The following is a description of a gene set: Human Gene Set: GOCC_CATION_CHANNEL_COMPLEX An ion channel complex through which cations pass. species: Homo sapiens, and this is the list of marker genes: DLG2, KCNMA1, CALM3, ATP5PB, KCNB2, HTR3B, KCNN1, AKAP6, ABCC8 (NCBI Gene Id 6833), CALM1, KCNJ11, ATP5PD, KCNMB1, KCNH1, KCNG2, CATSPER3, TRPV6, GRIK2, PDE4D, KCNN4, SCN11A, KCNJ4, KCNK1, CHRNA6, AMIGO1, SCN9A, KCNA6, KCNK6, CACNA2D1, LRRC55, SCN5A, MICU2, TRPC4, SCN2B, TRPC1, FKBP1B, DLG4, CACNG3, STAC3, TRPC3, TMEM262, PKD1L1, KCNQ1, ATP5MC3, CNGB3, KCND2, KCNG4, KCNQ2, PKD2, HCN1, KCNH2 (potassium voltage-gated channel subfamily H member 2), CATSPERD (NCBI Gene Id 257062), KCNJ2, TRPC5, KCNK2 (potassium two pore domain channel subfamily K member 2), CACNA1B, KCNJ9, CACNB2, KCNJ8, TRPM4, CACNA1F, KCNV2, PDE4B, CACNA2D4, CACNG2, CACNG6, KCNQ4, CNGB1, GRIK4 (glutamate ionotropic receptor kainate type subunit 4), ATP5ME, GRIK5, MICU1, CATSPERB, CACNB4, ABCB8, KCNJ6, ATP5PO, MCUB, CTTN, UNC80, MT-ATP8, GRIK3, CACNA1I, KCNC2, KCNA5, CNGA3 (cyclic nucleotide gated channel subunit alpha 3), HCN4, KCNA4, KCNQ5, CACNG1, ATP5MC1, AKAP9, SCN1A, ATP5F1E, VAMP2, KCNE1, KCNH5, CATSPER1, TMEM249, KCNIP2, C2CD6, CATSPER2 (cation channel sperm associated 2), SCNN1B, CHRNB2, PKD1L3 (NCBI Gene Id 342372), SCN3A, CACNA2D2, HSPA2, HCN2, CATSPERG, KCNE2 (potassium voltage-gated channel subfamily E regulatory subunit 2), KCNG1, SCN3B, CHRNA4, CACNA1A, DPP10, LRRC52, KCNF1, HTR3A, KCNA10, CACNB3, ATP5MJ (ATP synthase membrane subunit j), ATP5MC2, SCN10A, KCNQ3, HTR3C, CASQ2, KCNS3, TRPV5, KCND3, KCNV1, EFCAB9, ASPH, CNGA2, KCNMB2, LRRC38, DPP6, SMDT1, MT-ATP6, SCNN1D, CACNG7, CHRNA2, HTR3D, KCNS1, CACNA1D, ATP5MF, ATP5F1C, CCDC51, STX1A, HTR3E, CHRNA7, KCNB1, CATSPER4, MCU, HCN3, CACHD1, CNGA1, CHRNB3, KCNA3, ABCC9, PKD2L1, ATP5F1EP2, TRPC7, KCNAB2, PRKACA, LRRC26, SCNN1A, KCNK4, ATP2A1, KCNC1, ATP5MK, CACNG4, RYR2, KCNA1, PTPA, KCNAB1, CACNA1E, KCNG3, KCNAB3, CALM2 (calmodulin 2), SCN7A, MICU3, PKD1, RYR1, CNGA4, DMAC2L, KCNIP3, SCN2A, CACNA2D3, KCNA2, GRIK1, ATP5MG, SCNN1G, KCNC3, SCN4A, KCNH4 (NCBI Gene Id 23415), CACNA1C, CACNA1H, CACNG8, ORAI1, CATSPERZ (catsper channel auxiliary subunit zeta), CACNA1G, SCN4B, KCNJ5, CATSPERE, ATP5MGL, CACNA1S, KCNS2, SESTD1, ATP5F1A, CHRNA3, KCNIP1, ATP5F1D, CNTNAP2, FKBP1A, KCNE4, SNAP25, KCNIP4 (NCBI Gene Id 80333), KCNMB4, KCNMB3, RYR3, KCNE3, CHRNB4, KCNJ16, KCNJ14, SCN8A, KCND1, CHRNA5 (cholinergic receptor nicotinic alpha 5 subunit), ATP5PF, KCNA7, TRPC6, KCNC4, ATP5F1B, KCNE5, SUMO1, KCNJ3, CACNB1, SCN1B (sodium voltage-gated channel beta subunit 1)